Given this list of marker genes MAPK6, STAT3, VAX1, GPR183, ARID4A, CARD10, YPEL1 (NCBI Gene Id 94021), PFN2, HESX1, CCDC14, CFAP161, BNIP2, AARD, CHRNA3, NTRK2, FBXO21, LSM5, PAFAH1B1, ZFHX4, MIGA2, PTPRG, AGO1, REEP1, TNRC6C, UQCC1, RECK, TOB1, HDDC2, DUSP18, UBR5, CLOCK, ZNF213, ZRANB1, GPR137B, GDAP2, PARP1, FEZ2, FMNL3, HAND2, here is a description of the gene set: Genes predicted to be targets of miRBase v22 microRNA hsa-miR-371b-3p in miRDB v6.0 with MirTarget v4 prediction scores > 80 (high confidence targets). species: Homo sapiens Human Gene Set: MIR371B_3P from publication Chen Y, Wang X (PMID 31504780)